Given this list of marker genes Gsk3b, Jak2, Sh2b3, Il3ra, Gsk3a, Jak1, here is a description of the gene set: Mouse Gene Set: GOBP_RESPONSE_TO_INTERLEUKIN_3 Any process that results in a change in state or activity of a cell or an organism (in terms of movement, secretion, enzyme production, gene expression, etc.) as a result of an interleukin-3 stimulus. species: Mus musculus